The following is a description of a gene set: studied in species Homo sapiens from publication Cui Y, Zheng Y, Liu X, Yan L, Fan X, Yong J, Hu Y, Dong J, Li Q, Wu X, Gao S, Li J, Wen L, Qiao J, Tang F (PMID 30759401) Human Gene Set: CUI_DEVELOPING_HEART_VASCULAR_ENDOTHELIAL_CELL, and this is the list of marker genes: KLHL13, TRIM22, FBLIM1, IER2, PDE4B, MMP28, CPE, SLC41A3, ADAMTS1, CST3, ICAM1, IGFBP7, PER1, CDC42EP3, LTBP2, KAZALD1, ASS1, NNMT, HSPA1B, RTN4RL2, ZFY (zinc finger protein Y-linked), SWAP70, TNKS1BP1, BST2, MRC2, PIGT, PTGDS, ELN, MPZL2, MYH9, SERPINE2 (serpin family E member 2), CDH23, DHH, CXCL3, SYNGR2, CTSD, IGFBP2, FBLN2, SULF1, TOB1, GABARAPL2, APLP2, IER5L, EFNA5, EMP2, OS9, NFKBIA, GJA5, DHRS3, SDF4, SEMA3F, GAS6, SERPINE1, TENT5A, FBLN5, THBD, NES (NCBI Gene Id 79662), FXYD5, CFI, CLIC3, NPDC1, DEPP1, CKB, ZFP36, PTN, GLT8D2, MALL, RAMP3, KLF4, COL1A1, PDGFD, HSD17B12, OMD (NCBI Gene Id 4958), CXCL2, MTUS1, MIR23AHG, CARD16, CD320, SFRP4, ADH1B, ABI3BP, COL5A2, FGL2, SELENOM, BGN, RGS5 (regulator of G protein signaling 5), LOX, AIF1L, CREB5, JUN, PI16, DPP7, FAM3B, GADD45B, GLG1 (golgi glycoprotein 1), CLEC14A, GASK1B, SFRP5, FOSB, RHOB (ras homolog family member B), MECOM, PXDC1, VCAM1, CFH, SLC7A8, BCAM, ALDH1A1, LTBP3, SULT1E1, CYTL1, IL11RA, TSPAN7, TCN2, EFEMP1, ATP6AP1, SULF2, GJA1, METRNL, KLF2, GATA2, NFIX, ADCY4, TSC22D1, GABARAPL1, TSPAN2, ITSN2, HEG1, BHLHE40, LIMS2, HSPA1A, PROCR (NCBI Gene Id 10544), GOLIM4, KCNMB1, MAP3K8, AHNAK2, PI15, SFRP1, MET, KCNN4, CLU, CPXM2, MMRN2, ECM2, HAPLN3, LSR, GRN, TXNIP, EMP3, PPIC, HTRA1, PDGFRL, ANKRD36B, SEZ6L2, LTC4S, LINC01133, DDIT4, PTPRF, CBLN2, TNFAIP3, COL5A1, NEIL1, SIK1, CTSK, PPP1R15A, LTBP4, ASPN, NUCB2, MEGF6, DKK2, CD151, BTG2, LIMA1, PTGS1, COL9A3, CD58, HEXB, C1R (complement C1r), RASD1, MEIS2, IFI27, MGP (matrix Gla protein), CRIM1, MFAP2, CPAMD8, TMEM120A, IFI6, CRTAC1, SKIL, JUNB, MMRN1, CXCL1, SH3RF1, MMP2